The following is a description of a gene set: Human Gene Set: HEN1_02 studied in species Homo sapiens Genes having at least one occurrence of the motif NNGGGNCGCAGCTGCGNCCCNN in the regions spanning 4 kb centered on their transcription starting sites. This matches the NHLH1 transcription factor binding site V$HEN1_02 (v7.4 TRANSFAC)., and this is the list of marker genes: KCNMA1, HOXB5, SLC44A2, CBFA2T3, CBX6, PPTC7, CDK2, CLINT1, CALM2, LINC02875, LOXL4, RIMS1, RAB1A, NRG1, TEX35, C11orf52, MYO18B, MRPL14, C6orf62, PTK7, ASB16, IMPDH1, BMP4, VPS45, EDC4, NR4A3, CREB3L1, SPAG6, SMG5, E2F1, ZBTB16, OLFML2A, LRRN3, ZNF574, PCGF1, SULT2B1, UBE2D3, RBX1, BCL9L, DOCK4, BAHD1, GPD1L, F11R, POFUT1, HSD3B7, RAB27A, TCF4, KMT2A, SIX5, PLXNC1, TXNDC12, BCAS4, BAZ2A, BRSK2, FES, CYP4V2, MGAT1 (NCBI Gene Id 4245), PTCHD1, UNC119, TMEM8B, SOX14 (NCBI Gene Id 8403), PRKACA, JADE1, TGIF1, ESRRG, ZNF384, MOSPD1, ASB2, DOC2B, APLN, CALCOCO1, HS3ST4, CBX4, RPIA, DLL3, MFAP4, NOL4, ABCB9, ZNF513, ZFP91, PTGDS, STAT3, NR4A2, MRGPRF, SOST, KCNN2, GABBR2, GRIN2D, DPF3, LYPD1, FAM131A, SEPTIN3, PNCK, ANK2, NDUFA4, IRF2BPL, DAAM1, SPEG (striated muscle enriched protein kinase), TIMM10B, PLPP7, CALM3, CDK15, ARHGAP5, GSTT4, ZMYM4, USP5, ALX3, PRKACG, PHOX2A, SHCBP1L, PEG10 (paternally expressed 10), CCDC106, KLF8, ETV5, EIF4G2, CDC42EP3, FAM13B, TMEM79, TRIM46, NEUROD2, ARL4A, TRERF1, ANKRD42, LSR, NEDD4, PURA, CCNE2, SLC29A4, RELA, JOSD1, MLLT11, PSME1, DUSP7, ARFIP2, PDGFB, HOXB8, TECPR1, GGNBP2, SLC44A1, PPP1R16B, FNDC5, EIF4G1, SOBP, CHMP4B, MEGF10, KLK3, VSX2, CHPF, KCNQ1DN, GALNT10, BCL2L2, SMARCA5, ADAM15, CAPN5 (NCBI Gene Id 7445), SPATC1L, JAG1, ENO3, OGFOD2, PRPF38B, ADAMTS2 (NCBI Gene Id 9509), MYC, KLHL1, CELF1, OSBPL10, NLGN3, TBX3, CHD4, PLAGL2, ATP13A1, RASL10B, GNG8, IGF1, LRP5, MAP1A, SPACA6, KRTCAP2, ABTB2 (NCBI Gene Id 25841), ZBTB18, PHLDB1, STMN2, HYAL2, CDC42SE1, LOXL1, ROCK1, PARP8, GIPC1, SLC22A17, LZTS2, TSHZ3, CACNB2, AMPD2, VAMP1, MYT1, IRX2-DT, BCL6B, RTL9, ENKD1, CRB1, PRICKLE1 (prickle planar cell polarity protein 1), ZNF232